The following is a description of a gene set: Distal convoluted tubule 1 (DCT1) cell species: Mus musculus Mouse Gene Set: WP_DISTAL_CONVOLUTED_TUBULE_1_DCT1_CELL, and this is the list of marker genes: Cab39, Wnk4, Kcnj16, Wnk1, Stk39, Slc12a3, Clcnkb